Given this list of marker genes POLRMT, SLC30A9, NUP160, UMOD, SLC4A2, here is a description of the gene set: Human Gene Set: HP_STAGE_3_CHRONIC_KIDNEY_DISEASE studied in species Homo sapiens A type of chronic kidney disease with moderately reduced glomerular filtration rate (GFR 30-59 mL/min/1.73 m2). Stage 3 chronic kidney disease